The following is a description of a gene set: Pathway Definition from KEGG: NODAL -> ((ACVR2A,ACVR2B)+(ACVR1B,ACVR1C)) -> (SMAD2,SMAD3) == SMAD4 Nodal signaling pathway. Pathway ID: N01459. Pathway type: Reference. Pathway class: nt06507 TGFB signaling. studied in species Homo sapiens Human Gene Set: KEGG_MEDICUS_REFERENCE_NODAL_SIGNALING_PATHWAY, and this is the list of marker genes: ACVR2B, SMAD3, ACVR2A, SMAD4, NODAL, ACVR1B, ACVR1C, SMAD2